The following is a description of a gene set: Mouse Gene Set: GOMF_HYDROXYMETHYL_FORMYL_AND_RELATED_TRANSFERASE_ACTIVITY Catalysis of the transfer of a hydroxymethyl- or formyl group from one compound (donor) to another (acceptor). species: Mus musculus, and this is the list of marker genes: Atic, Shmt2, Shmt1, Ftcd, Gart, Amt, Mtfmt, Gcsh